The following is a description of a gene set: studied in species Mus musculus Any process that modulates the frequency, rate or extent of protein polyubiquitination. Mouse Gene Set: GOBP_REGULATION_OF_PROTEIN_POLYUBIQUITINATION, and this is the list of marker genes: Gabarap, Ube2n, Xiap, Foxf2, Nmi, Prkn, Spsb4, Parp10, Tcf25, Hamp2, Trim44, D1Pas1, Sash1, Hamp, Ptpn22, Ttc36, Birc3, Ube2d1, Marchf7, Ppia, Dysf, Ube2v1, Cep63, Ube2v2, Birc2, Ripk2, Plaa, Fbxo4, Nod2 (NCBI Gene Id 338538), Rnf40, Gps2, Ddx3x, Skp2